Given this list of marker genes SELL, RIPOR2, PTPN6, FMNL1, CORO1A (NCBI Gene Id 11151), ARPC3, LRCH4, TRIM38, CNPY3, WAS, LSP1, ACAP2, GPSM3, MCL1, ARRB2, DAZAP2, USP3, LRRFIP1, LYN, ICAM3, CD53, CASP4, JUNB, CASP1, EVI2B (NCBI Gene Id 2124), TCIRG1, CMTM6, OSBPL8, PAK2, DPEP2, ARHGDIB, MX2, HLA-B, CYTH4, HSD17B11, MYD88, GMFG, RNASET2, HCLS1, GMIP, SKAP2, LAPTM5, GIT2, FXYD5, STAT6, B2M, THEMIS2, here is a description of the gene set: Neighborhood of SELL species: Homo sapiens Human Gene Set: GNF2_SELL Neighborhood of SELL selectin L (lymphocyte adhesion molecule 1) in the GNF2 expression compendium